Given this list of marker genes Slc27a5, Abcd2, Hacd2, Pex2, Abcd1, Elovl5, Hacd3, Slc27a2, Abcd4, Acox1, Abcd3, Acsl6, Elovl6, Acsl1, Elovl4, Acaa1a, Pex5, Tecrl, Acot5, Elovl2, Acox2, Elovl7, Hsd17b4, Elovl3, Hacd1, Hacd4, Elovl1, Slc27a4, Acot4 (NCBI Gene Id 171282), Acsbg1, Acot2, Tecr, Acot3, Acaa1b, here is a description of the gene set: The chemical reactions and pathways involving a very long-chain fatty acid. A very long-chain fatty acid has an aliphatic tail containing more than 22 carbons. studied in species Mus musculus Mouse Gene Set: GOBP_VERY_LONG_CHAIN_FATTY_ACID_METABOLIC_PROCESS